Given this list of marker genes NFATC3, CXCL12, CALM2, PLCB4, PLCB2, NFATC2, PPP3R2, PLCG1, CALM3, CXCR4, NFATC1, PPP3CA, PLCB1, PLCB3 (NCBI Gene Id 5331), PPP3CB, GNAQ, PPP3CC, PLCG2, CALM1, PPP3R1, NFATC4, here is a description of the gene set: Pathway Definition from KEGG: CXCL12 -> CXCR4 -> GNAQ -> (PLCB,PLCG) -> IP3 -> Ca2+ -> CALM == CN -> NFAT studied in species Homo sapiens CXCR4-GNAQ-PLCB/G-calcineurin signaling pathway. Pathway ID: N00401. Pathway type: Reference. Pathway class: nt06161 Human immunodeficiency virus 1 (HIV-1). Human Gene Set: KEGG_MEDICUS_REFERENCE_CXCR4_GNAQ_PLCB_G_CALCINEURIN_SIGNALING_PATHWAY